The following is a description of a gene set: Osteoblast differentiation and related diseases Human Gene Set: WP_OSTEOBLAST_DIFFERENTIATION_AND_RELATED_DISEASES studied in species Homo sapiens, and this is the list of marker genes: WNT4, HES2, JAG2, FZD8, FGF2, FZD5, PIK3CA, GLI3, FZD1, FGF3, FZD9, FGF7, WNT9A (NCBI Gene Id 92832), WNT5A, PIK3R2, PRKCG, PIK3CB, PIK3R3, FGF10, PRKD1, MAPK11, HES6, WNT7B, FZD3, FGF5, WNT2, SMAD9, FZD2, NOTCH3, LRP5, PIK3CG, PIK3CD, FGF1, SMO, JAG1, WNT8B, SMAD4, WNT8A, PTCH1, PIK3C2G, LRP6, PRKCH, WNT11, IHH, PRKCD, BMPR1A, HEY1, STAT1, BMP4, WNT10B, FGFR1, MAPK12, WNT16, PIK3R6, MAPK13, FGF6, WNT6, FZD6, PIK3C2B, MAPK4, WNT9B, MAPK3, SMAD5, WNT10A, FGFR3, BMPR1B, FZD7, PRKCQ, NOTCH4, BMP2, FZD10, MAPK6, WNT2B, WNT7A (Wnt family member 7A), PIK3R1, WNT1, WNT3 (Wnt family member 3), FGFR2, RUNX2, SOX9, MAPK1, SMAD1, BMPR2, MAPK10, PRKCZ (protein kinase C zeta), FGF9, PIK3C2A, NOTCH2 (notch receptor 2), MYOD1, PRKCA, DLL4 (NCBI Gene Id 54567), MAPK7, DLL1 (NCBI Gene Id 28514), NOTCH1, FGF18, PRKCI, PIK3C3 (phosphatidylinositol 3-kinase catalytic subunit type 3), FGFR4, RBPJ, HES3, CTNNB1, FGF4, DLL3, PIK3R4, PPARG (NCBI Gene Id 5468), GLI2, WNT5B, MAPK9, MAPK8, FGF8, PRKDC, WNT3A, HEY2, FZD4, PRKCB, PRKCE, PIK3R5, MAPK14